The following is a description of a gene set: from publication Elo LL, Järvenpää H, Tuomela S, Raghav S, Ahlfors H, Laurila K, Gupta B, Lund RJ, Tahvanainen J, Hawkins RD, Oresic M, Lähdesmäki H, Rasool O, Rao KV, Aittokallio T, Lahesmaa R (PMID 20620947) Genes down-regulated in comparison of untreated CD4 T cells at 0 h versus the untreated cells at 24 h. studied in species Homo sapiens The aim of this dataset was to study in detail the transcription kinetics initiated by cytokine IL-4 in early differentiation of Th2 cells. Human Gene Set: GSE17974_0H_VS_24H_IN_VITRO_ACT_CD4_TCELL_DN, and this is the list of marker genes: RAD50, SCFD2, CDC25A, EIF2B2, ZNF239, ELP5, UTP11 (NCBI Gene Id 51118), TIPIN, FDX2, WDR12, PFAS, SF3B3, IL2RA, MRE11, ZNF780A, RAD54L, COA7, NCBP1, MOCS3, RCC1L, PAM, UBE2C, CKS2, PPIL1, DTYMK, POLA2, TNFRSF9, SLC39A14 (NCBI Gene Id 23516), GALE, NT5C, EXOSC2, RAD51, RBBP8, ACOT13, HOMER1, AURKA, PRDX4, ANXA4, CDK2AP2 (NCBI Gene Id 10263), PGBD2, GK3, GFOD1, ZNF443, PRAME, MRPL17, MLKL, FSCN1, RBM14, TCF19, TSEN2, PAGR1, LIF, EIF2B3, PRC1, PDAP1, CD200, DCPS, CHAC2, B3GNTL1, C3orf52, FUT11, PARS2, STAP2, ZW10, WSB2, CCNA2, SDF2L1, UMPS, C4orf36, TEX30, GINS3, FAR2, EIF3J (eukaryotic translation initiation factor 3 subunit J), EXOSC3, MRPL35, RBM6 (NCBI Gene Id 646559), FABP5, RNASEH2A, MTNAP1, BCAT1, MRPL12, CENPM, PHF19, TRIP13, LZTR1, DHX58, NCAPG, MTMR2, MELK, SLC29A1, NAB2, DPAGT1, DNPH1, RCC1, TMEM165 (transmembrane protein 165), CCNE1, NEMP1, TIMM8A, LYAR, SMCO4, ATOX1, UCK2, CDKN3, CDK5, MMACHC, IRF8, IGFBP4 (insulin like growth factor binding protein 4), BAZ1B, TRMT2A, ZWILCH, CMSS1, MYBL2, FBXO22, POLR2F, POLR3K (NCBI Gene Id 51728), LRR1, EMC9, APOL2 (apolipoprotein L2), RAD51D, MIR155HG, PFKM, FANCE, TNFRSF4, WDR77, CD38, TRIM69, EGR3, PNO1, NDUFV3, PRPF38A, UBE2M, GLMN, CENPS, PRMT1, JMJD4, CHEK1 (checkpoint kinase 1), SNX12, CTPS1, MED20, TPX2, ID3, GM2A, RMI2, H2AX, POLR3D, TMEM106C, BIRC5, BLM, CDCA5, CHAF1B, STIP1, P3H1, SNRNP25, PIGV (phosphatidylinositol glycan anchor biosynthesis class V), C1GALT1C1, PDCD2L, LRWD1, ZNF232, AUNIP, LRRCC1, SMKR1, HCP5, RRP1, XCL1, SI, BCAT2, WDR41, SLC38A5, BDH1, ALYREF, SMG9, MCOLN2, TUBA4B, JPH1 (NCBI Gene Id 56704), SDC4, LTA, NUDCD1, PFDN6, DNAJC17, FAM200C, CENPJ, BRIP1, TBC1D7, TNF, SCO2, EXO1, PHF23, BYSL, TBX21, CKS1B, ZDHHC13, EXOSC4, CCDC86, GEMIN6, SLC19A1, TMEM140, GNGT2, SLC43A3